The following is a description of a gene set: studied in species Homo sapiens part of: Platelet Aggregation (Plug Formation) Adrenaline (epinephrine) signalling via the alpha-2 adrenergic receptor has many effects including inhibition of insulin release in pancreas, induction of glucagon release from pancreas, contraction of sphincters of the gastrointestinal tract, negative feedback processes in neuronal synapses and stimulation of platelet aggregation. This receptor preferentially couples to members of the Gi class of heterotrimeric G-proteins, leading to inhibition af adenylate cyclase and thereby decreased cAMP levels. Reactome Pathway: Adrenaline signalling through Alpha-2 adrenergic receptor, and this is the list of marker genes: ADRA2A, ADRA2B, ADRA2C (adrenoceptor alpha 2C)